Given this list of marker genes TBC1D5, NR2F2, TLE6, SMG8, LINC01780, NCAM1, NME5, ITGA7, TLE2, HNRNPA0, CAPZA2, CSRP2, ADGRL2, AAGAB, SSBP2, CEBPA (CCAAT enhancer binding protein alpha), BLOC1S1, HEXA, MYL6, TBL3, LINC00705 (NCBI Gene Id 338588), CASZ1, STX6, SRD5A1, BTG1-DT, STAG3L3, ILF3-DT, MIER1, SERTAD4, FZD1, GTPBP3, LZIC, AGPAT5, WDR62, SCARB1, SLC11A2, PAXBP1, LRP6, GNAL, FNTB, ECI1, SEMA6A, SLC25A53, GATC, MTERF4, G6PC3, TAGLN2, WDR25, FAM187A, RDUR, C19orf47, DDX41, REV3L, TRDMT1, CHFR-DT, CLASRP, DDX10, HOXA10, INTS12, ISY1, YWHAZ, RGMB-AS1, TMEM248, ARHGAP26, MS4A8, SERTAD3, PUSL1, KANSL2, ATG5, HLA-DMA, PPFIA3, CLASP2, DST, MRPS15, SPOP, POLD1, TGFBI, LBX1-AS1, RNF150, METAP2, MEGF8, USP30, RPL39P40, LMF1, NRIP3-DT, EDC4, BMS1, ARID1A, PEPD, BRPF1, HDAC2-AS2, AK4, TSC22D4, ZNF77, GMNN, OGDH, PDZRN3, HOXA-AS3, COX5A, PDXK, DST-AS1, CLPB, EYA1, LRRC37A5P, FRMD4B, DNAJC18, SLCO4A1-AS2, FGD4, FAN1, DVL2, MIR194-1, OCIAD1, LURAP1L-AS1, THOC6, CROCCP3, DPY19L3-DT, LINC02609, CSNK1D, PPP5D1P, GABBR1, ERBB3, ZNF827, RNU6-920P (RNA, U6 small nuclear 920, pseudogene), NTMT1, PBX1-AS1, KLHDC10, LINC00680 (NCBI Gene Id 106660612), OSBPL8, ATF3, MACIR, NR2F1, ATXN2L, CFDP1, KRT18P12, RAB5A, COPS7A, CACYBP, RPL26L1, BRD2, PRSS23, ADPRS, TLE3, CCDC136, CDIP1, ERAP1, EPRS1, FNDC3B, SMAP2, LINC02756, PAF1, RNU6-1039P, INSM1, MED13L, RCN1, MAP3K5, NUDT18, IGFLR1, LINC02794, CABLES1, VLDLR-AS1, MTRFR, SNX10-AS1, CCBE1 (NCBI Gene Id 147372), CDKN2AIPNL, SMAD4, SUMF1, HOTAIRM1, MXI1, ENC1, LINC02846, REV1, GABARAP, ASH2L, NECAP2, PRKAR1A (protein kinase cAMP-dependent type I regulatory subunit alpha, NCBI Gene Id 5573), NME1-NME2, SMG5, RBM28, CYP4X1, AURKAIP1, TRUB1, HOXA5 (NCBI Gene Id 55953), CASC3, PAFAH2, RERE, NEURL4, ARHGEF1, HPS5, GPNMB, GALNTL5, MIR6768, CEROX1, ZNF503-AS2, MIR615, MYG1, LIMA1, FCHSD2, EFNA1, ENSG00000232995, USP32, NDC1, CASC18 (cancer susceptibility 18), PPM1H, EPB41L4A-AS1, CCAR2, NRP1, ATOH1, TENM3-AS1 (NCBI Gene Id 90768), CCDC8, MYL6B-AS1, TEFM, RN7SL446P, CAPNS1, LINC02832, MTG1, BACH2, NCBP2AS2, TASOR, SKAP1, GAPDH, RNU6-1109P, SREBF1, GUSBP2, H3-3A-DT, ASAH1-AS1, MIR4530, RANBP3L, PRKG1, NXN, MRPS31, KCNIP2, MDM2, DOC2A, PXN (NCBI Gene Id 80229), TRAF3IP2-AS1, CCT6B, ATP6V0D1, SLC9A1, EIF2B1, HARS1, PCDH7, CNIH3, NCOA7, DYNC2I2, FAM21EP, ARMT1, MAGI2, CDC14A, ZEB2, TM7SF3, ELAPOR2, PKM, AMACR, GTF2IP20, PAX6, VPS51, PDCD6P1, PAFAH1B3, ARID4B, PSMD12, ALDH1A2-AS1, RAB2A, CIC, COA1, SLC39A3 (solute carrier family 39 member 3), VWA8, KRT19P2, HOOK2, MRTFB (myocardin related transcription factor B), S100A2, SCARNA17, PPFIBP1, SECISBP2L, RFC1, FZD2, NDUFS3, PCCB, DR1, SEPTIN7P13, BRWD1, PDE4A, BCKDK, PDE8A (NCBI Gene Id 5151), LINC01116, RMND1, DNAJC9-AS1, HOXB5, HEXA-AS1, EIF2D (NCBI Gene Id 1939), SIAH1, NOSIP, TCF4, EIF4E2, HEATR3, TMEM260, JAGN1, SF3A3, IGF2BP3, ZBTB45, RFTN1, SLC24A1, LMNB1-DT, TXNDC11, UCHL5, SEC13, ZNF529, XPC-AS1, NIPSNAP2, MALAT1, ADAT2, ASB2, MAGI1, NAPA-AS1, ATP6V1H, MYO3A, PMAIP1, ANKRD10, AIG1, ARHGAP28, DUT, MTND2P17, LMTK2, PAQR8, GLI3, PEX3, PGAP1, GFRA3, PPP1R16A, PRKCI, NREP, MET, DPP9, ACAA2, MTFR2P2, SLC18A1, CFAP74, MLEC, CHFR, KLHL32, GTF2H1, ALDH1A2, LINC01144, CAMK2N1, INO80B-WBP1, HOXB3, MTUS1, MAPK6, VAV3, MTND4LP24, PIM1, ODAD2, B4GAT1-DT, MTARC1, THAP8, TMEM242-DT, FLNA, C1orf21, SMG7-AS1, ZNF217 (zinc finger protein 217), MGC32805, TOB2, CCDC159, ARHGAP24, ASCC1, H3-3A, B4GAT1, DNAJC25-GNG10, SETD1A, PRUNE2, MCOLN3, RGS16, MIOS-DT, SLBP, FTO, CLPTM1, UTP4, ZCCHC24, PTPN2 (protein tyrosine phosphatase non-receptor type 2), CASTOR3P, SPNS1, KCNK5, NAGPA, RBBP7, WDR47, YTHDF1, ZMIZ1-AS1, WDFY3-AS2, TOR1A, PRPF18, EMX2OS, PYCR2, TMEM108-AS1, PRDX1, MAP3K7, PRDM6, PRRG2, CLN8, UBAP2L, PHC2, SNAP47, RPL27, METTL25, GAPDHP14, RPL26L1-AS1, FAM168A, PTPRG, PHC2-AS1, ITGB3BP, ENSG00000224865, DNM1L, DZIP1L, NKIRAS1, PNRC1, CDC42EP4, TFAP2A, DECR2, SKIDA1, ISY1-RAB43, BCAN-AS2, MAPK4, ANP32B, NEAT1, CDKN1C (NCBI Gene Id 702), CREM, MOB4, CCNE1, DGAT2, STRA6, CZIB, TLE4, NAV2-AS4, DNAI4, KBTBD4, ELP3, JPX, SART3, HOXA9, HOXA3, PIK3R3, OTULIN-DT, COQ10A, PCGF3, NCOR2, CTSA, HOXC5, SEPTIN7P14, SRFBP1, ENSG00000235480, LINC01976, PEG10, RAD52, SYNCRIP, PPP1CC, INTS14, TSKU, EFCAB14, BBX, GPATCH3, DLC1, RPL37, ESPL1, ERC1, ZNF674-AS1, HOXB9, PPCDC, DACH1, ARNT, LAMP1, USP35, HEXIM1, C6orf226, DISC1, BHLHE22-AS1, DUSP6, MPP1 (MAGUK p55 scaffold protein 1), CREB3L2-AS1, ICA1L, SNRPF-DT, CCDC18-AS1, LINC01547, HOXC4, ELFN1-AS1, ABHD2, E2F2, STX18-AS1, HBP1, EPCIP-AS1, LMNB1, CNOT6, ZNF608, SMAD1, YBX3, MED23, GNB2, S100PBP, MARCHF8, BCL9, CZIB-DT, HOXA-AS2, RALGDS, LSM5, ETV2, UNC13B, SMG7, UBE2S, DYNC1I1 (dynein cytoplasmic 1 intermediate chain 1), HSP90AA1, HOXB-AS3, VGLL4 (NCBI Gene Id 9686), ZNF771 (NCBI Gene Id 51333), ZIC2, MIB2, NEURL2, CFAP206, LTBP1, MMAB, INO80C, POLR3E, KCTD21, CNIH3-AS2, RBBP5, KCTD19, LINC02614, LRP1B, SSU72, RESF1, DDX55, PLK3, ZC3H6, PARK7, EFNA5, USP3, SMG1P3, CTNNB1, GARNL3 (GTPase activating Rap/RanGAP domain like 3), TNC (NCBI Gene Id 3371), TIPARP, GNGT1, LY6K, EFTUD2, MYOM2, EFHC1, PGS1, ATXN7L1, CDC73, HOXD11, TMEM255A, DTNA, WWTR1, YARS1, HOXB8, GAPDH-DT, KRT13, FAT3, DNAJB6, PBX3, XPOT, CALM3, ANKDD1B, PARP6, NOP16, GSTO1, CENPU, ENSG00000226087, SSU72-AS1, GPR85, PDCD7, ZNF674, SLC25A16, SF3B6, STMND1, ZFP1, ENSG00000247416, RGS12, ZNF274, LINC00431, GDE1, HNRNPF, EPHA4 (EPH receptor A4), ALOXE3P1, PPP2R5C, SEMA6D, SCAT2, NMNAT1, SCAPER, BRWD3, SNORA13, GBA1, DCAF8-DT (NCBI Gene Id 100509745), RPS6KA5, EXTL3, KBTBD11-OT1, ALG10, LRRC36 (NCBI Gene Id 55282), NCBP2, CDKN2C, MAGOHB, AOPEP, MXD3, HUS1, CHCT1, CDKN1B, DYNC1I2, EPB41, MPHOSPH9, NME1, RPS27, COL17A1, JMJD4, PLPP5, TMEM79, WASHC2A, VTA1, SIX1, BPTF, SLC44A1 (NCBI Gene Id 63942), SMG9, PAWR, CEBPG, FRMD6, MPP7 (NCBI Gene Id 143098), TCF3, TCP11L2, NET1, NUS1, LGI4, MAGI2-AS3, LRRC59, GTF2IP12, NSUN2 (NCBI Gene Id 54888), ZBTB20, CAV1, SLC30A10, HSPA1B, TBC1D4, POC1B-GALNT4, RPS15, DPY19L3, MIR4512, MIR4727, MCTP1, TIPARP-AS1, CALM2, RPS3A (NCBI Gene Id 6189), CUEDC2, NFIA, ACTBL2, GAS1, ENSG00000277270, LINC01275, CCDC192, COG1, MVK, ETV4, AMPH, ALKBH3-AS1, CWC25, ANO8, BAX, BDP1, ATAD3A, LINC01091, LINC02831, SAMD4B, HNRNPAB, WNT5A, CHTF8, MTF2, NUF2, ARF6, TTI2, TENM3, C15orf61, HTR3B, KLRK1-AS1, NR1H2 (NCBI Gene Id 7376), ATG7, THAP3, SMIM13, RCOR1, FNTA, EFCAB7, ACAT2, GOLGA3, SOX8, TXLNB, ANK1, MTHFR, CCDC59, MYL12A (NCBI Gene Id 10627), HIVEP3, HEATR3-AS1, TSKU-AS1, CCNG2, STAP2, TMEM242, MAP1LC3B, C2CD5, FBXO31, RPS19, SSBP1, IGF1R, CHN1, TRIAP1, SAYSD1, MECOM, KCNK1, SLC35F1, ARHGEF7, PLD3, NUP133-DT, MCC, TIPIN (TIMELESS interacting protein), NBPF19, ZNF839, FANCA, TRIM39, NUAK1, CABLES2, ASXL3-DT, STX8, POC1B, ETV5, WDFY3, SNAPC5, NOP14, SATB1, CYTH1, ACAP3 (NCBI Gene Id 80855), CHD2, MRPL12, SGCE, HDAC2, ADD3, ALKBH3, MTND3P13, HARS2, MED14, HCFC1R1, FOXJ3, H4C8, ASB5, RPL15, FAM228B, LINC01023, KIAA2013, TSHZ2, RPS26, LINC01237, ISLR2, DGLUCY, MYO5C, IDI1, APPBP2-DT, HP1BP3, KCNB1, ZNF461, IQCH-AS1, SNRPF, C1orf21-DT, CACNB4, KIAA0319, CELF4, LINC01411, RO60, MRPL34, PRDM6-AS1, ADAP2, STAT6, CLDN7, TIGD1, NR2F1-AS1, PARN, MAPK6-DT, HINT3, RAD51-AS1, LAMA4, LINC01010, DPY19L2P2, TPM1, RNF43, SPINT2, RRAS, MTND4P34 (NCBI Gene Id 107075308), SCN1B, IQCH, RPP21, HEPHL1, ILF3, TNRC6A, REXO4, CLCN6, ASXL3, DRG2, ENPP3, MED29, FHL1, USE1, RGS5, ZKSCAN3, CEBPA-DT, VPS33A, POLR2J3, SNHG17, SLC8A2, DGAT2-DT, GOLM2, SLC25A37, MRPL1, ACTR8, LINC02901, ERLIN2, ATP9B, HNRNPH2 (NCBI Gene Id 3188), PRECSIT, ZNF529-AS1, ZNF503, STAT3, WTAP, SH2B3, IPO9-AS1, GLA, DDX46, SMARCD2, ZNF555, ALG1, ARHGAP15, PTBP1, SELENBP1, CGA, DTWD1, SRCAP, NUP133, RPL36AP8, EFHB, EMX2, CLN3, AP1G1, ASAH1 (NCBI Gene Id 79795), RAB40C, ENSG00000254251, GSTCD, AP2S1, VDAC2, SUDS3, RNF217, CCDC103, CACNB3, SLX9, N4BP1, STX18, RNU7-27P, MCPH1-AS1, FAM227B, RAD51, LINC02044, GGPS1, LINC00240, CLIC4, BZW1, ARHGEF12, RPS13 (NCBI Gene Id 6207), NFE2L2 (NCBI Gene Id 4780), ELSPBP1, INO80B, MIR1273C, WDR37, APPBP2, C1orf43, ECH1, METTL9, LINC01778, ATP1A1 (NCBI Gene Id 476), GNG12-AS1 (NCBI Gene Id 100507799), C6orf136, NFIB, KPTN, ZNF212, MPND, GRK4, FAM66B, LINC02709, FERMT2, ATP6V0D1-DT, ATP11C, OTULIN, YJU2B, WEE2-AS1, PBX3-DT, CACUL1, ARID2, SNHG22, DPP8, CCN1, DNAJC25, GTF2H3, LUC7L3, TBL1X, SCARNA2, here is a description of the gene set: from publication Yevshin I, Sharipov R, Kolmykov S, Kondrakhin Y, Kolpakov F (PMID 30445619) Genes containing one or more binding sites for (ZNF843) in their promoter regions (TSS -1000,+100 bp) as identified by GTRD version 20.06 ChIP-seq harmonization. Human Gene Set: ZNF843_TARGET_GENES studied in species Homo sapiens